Given this list of marker genes Snrpg, Lsm11, Zfp473, Snrpf, here is a description of the gene set: electronically inferred by orthology from the curated human pathway This event has been computationally inferred from an event that has been demonstrated in another species.<p>The inference is based on the homology mapping from PANTHER. Briefly, reactions for which all involved PhysicalEntities (in input, output and catalyst) have a mapped orthologue/paralogue (for complexes at least 75% of components must have a mapping) are inferred to the other species. Reactome Pathway: SLBP independent Processing of Histone Pre-mRNAs part of: Processing of Capped Intronless Pre-mRNA studied in species Mus musculus